The following is a description of a gene set: studied in species Mus musculus Mouse Gene Set: GOBP_CELLULAR_RESPONSE_TO_OXIDISED_LOW_DENSITY_LIPOPROTEIN_PARTICLE_STIMULUS Any process that results in a change in state or activity of a cell (in terms of movement, secretion, enzyme production, gene expression, etc.) as a result of an oxidized lipoprotein particle stimulus., and this is the list of marker genes: Tlr4, Cd68, Akt1, Smpd3, Myd88, Mexis, Mia3, Ticam1, Cd36, Tlr6 (NCBI Gene Id 21899), Trem2, Adtrp, Mir124a-1hg